Given this list of marker genes VAX1, HSF2 (heat shock transcription factor 2), SMYD3, NCOA2, VAX2, ZC3H8, ZNF350, HSF1, here is a description of the gene set: Binding to an RNA polymerase II intronic DNA sequence that regulates the transcription of the transcript it is contained within. Human Gene Set: GOMF_RNA_POLYMERASE_II_INTRONIC_TRANSCRIPTION_REGULATORY_REGION_SEQUENCE_SPECIFIC_DNA_BINDING species: Homo sapiens